Given this list of marker genes MT-TF, BOLA1, IER3-AS1, MT-RNR1, ROCK1P1, H2BC21, RN7SL600P, FLOT1 (flotillin 1), H2BC5, QRICH1 (glutamine rich 1), here is a description of the gene set: studied in species Homo sapiens from publication Yevshin I, Sharipov R, Kolmykov S, Kondrakhin Y, Kolpakov F (PMID 30445619) Human Gene Set: TUBG1_TARGET_GENES Genes containing one or more binding sites for (TUBG1) in their promoter regions (TSS -1000,+100 bp) as identified by GTRD version 20.06 ChIP-seq harmonization.